The following is a description of a gene set: species: Homo sapiens Human Gene Set: ZHONG_PFC_MAJOR_TYPES_ASTROCYTES from publication Zhong S, Zhang S, Fan X, Wu Q, Yan L, Dong J, Zhang H, Li L, Sun L, Pan N, Xu X, Tang F, Zhang J, Qiao J, Wang X (PMID 29539641), and this is the list of marker genes: RCN1, SNX5, GNG7, CBR1, TIMP1, TOR1AIP1, PRCP, UBL3, RHOC, ABHD3, MYORG, CSPG5, RGS20, NTRK2, AIF1L (allograft inflammatory factor 1 like), TBC1D10A (TBC1 domain family member 10A), KLHDC8A, NOTCH2, PDGFRB, LRRN3, HES5, TCIM, PREX1, CLU, TNC, ABCD3, ADGRB1, MYO10, AGT (angiotensinogen), SLC1A3, B3GLCT (beta 3-glucosyltransferase), BMAL1, GPR137B, DNER, HMGCS1, LRP4, CXCL14, COMT, DKK3, NOTCH3, ZFYVE21, CBS, TTYH1, ELOVL2, AQP4, STON2, RAB31, S1PR1, OLFM2, B2M, APBB2, IDI1, PMP22, ID1, PSAT1, SIRPA, EFNA1, PHGDH, GFAP, DBI, SEMA6D, ITM2C, ETV1, C1orf122 (NCBI Gene Id 127687), SYPL1, PDPN, FADS2, MFGE8, BRINP3, CASTOR1, TIMP3, CCDC80, EDNRB, EFHD2, LGALS3, GLUD1, SLITRK2, VCAM1, BBS2, SLC15A2, BCHE, SOX9, THBS3, CD82, TNFRSF19, GRB14, SEZ6L, KCNJ10, GPR37L1, ZFP36L1, SPARCL1, ID2, DBX2, LRRC10B, CA12, PNPLA3, DARS1, LINC00943, TRIL, IFITM3, MEIS1, CRYL1, SHISA4, HNMT, ADD3, PTN, IGFBP4, MT2A, PLCD1, HTRA1, ATP13A4, PRSS35, SPRY1, G6PC3, BCAN, ENHO, LIPA (NCBI Gene Id 3988), SLC4A4, DDAH1, SLC13A5, SOAT1, PEA15, HES1, TECPR2, SLC38A3, HSD17B12, IL33, WSCD1, ADGRG1, FABP5, SEMA6A, TTYH2, ELN, SPRY2, SLCO1C1, DTNA, EFEMP2, SASH1, LGALS3BP, GNG11, HOPX (NCBI Gene Id 84525), PLEC, PON2, LRRC3B (leucine rich repeat containing 3B), LRIG1, APOE, ABAT, ACSL6, ANOS1, RAB34, GPRC5B, TSC22D4, TSPAN7 (NCBI Gene Id 7102), MMD2, MRC2, SFXN5, GDPD2, LGI1, SLC1A2, LIX1, TSPAN3, TMT1A, SLC1A4, RAMP1, VEPH1, ATP1A2, FXYD1, GLUL, SPATA6, PRODH, RIT2, TFPI (tissue factor pathway inhibitor), AASS, GNG5 (NCBI Gene Id 2787), LAMB2, PAQR8 (progestin and adipoQ receptor family member 8), TRIB2, ADORA2B, ACSBG1, GRM3, FAT1, CTSL, BCAP29, SERPINE2, PLAGL1, TSPAN6, TEX264, TCF7L2, LITAF, PTPRZ1, RASSF4, SERPINB6, CAMK2G (calcium/calmodulin dependent protein kinase II gamma), LRATD2, HLA-A, FERMT2, VIM, EEPD1, GATM, YIF1A (NCBI Gene Id 10897), HAPLN3 (hyaluronan and proteoglycan link protein 3), PLPP3, NLGN3, GPX3, SLC25A18, HADHB, LUZP2, DCN, LYN, PHACTR2, SDC3, ZFP36L2, DDR1, CLDN10, GNPTG, SNX3, PPP1R16A, DOK5, BRINP3-DT, SCRG1, BTBD17 (NCBI Gene Id 388419), SLC3A2, AK4 (NCBI Gene Id 387851), BMP7, TRIM47, GNG12, KCNE5, CST3, FAM107A, CD63, ALDOC, ADCYAP1R1, F3, HAPLN1, MIR9-1HG, DCXR, HEY1, PDLIM5, GULP1, HSPB1, PHYHIPL, DAG1, NT5E (5'-nucleotidase ecto), HES4, FBLN2, HLA-C, ELOVL5, LRRC17, RFX4, GJA1, SOX2, SLC39A12, CDC42EP4, MT3, RGMA, CD9, MLC1 (modulator of VRAC current 1), JUN, NPNT, C3orf70, RAMP3, ANXA5, HLA-B, SOX8, MT1E, LGALS1, LRRTM3, ID4, P4HA1, NKAIN4 (NCBI Gene Id 128414), DHCR7, S100B, CPNE5 (copine 5), TP53I3, P3H4, PRR5, PTTG1IP, CDC42EP1 (CDC42 effector protein 1), SELENBP1, NDRG2, ATP1B2, ALCAM, PBXIP1, ETV5, MASP1, TM7SF2, GPM6B, FAM181B (family with sequence similarity 181 member B), NCAN, PDLIM3, PLEKHB1, MGLL, ROBO3, MSMO1, ITGAV, SCD, NHERF1, ITPR2, TMEM132B, QKI, NHSL1-AS1, ALPL, LEPROT, EMC2, ALDH6A1, MAGT1, SLC6A1 (NCBI Gene Id 6529), PLTP, SMIM30, BMPR1B, OAT, FABP7, ARHGEF26, BDH2 (NCBI Gene Id 641558), DIO2, C2orf72, PLIN3, LIFR, SPON1, CYP51A1, S100A13, RGCC, RAP1GAP, IFI27L1, S100A16, CNN3